Given this list of marker genes PDZRN3, TXLNG, SNRPD1, CREBRF (NCBI Gene Id 153222), DOCK3, SRF, DYNLL1, SMOC1, MARK1, PIM1, RBBP6, TOB1, PPP3CB, PUM2, DNAJC21, PTEN, PIK3R1, NEUROD6, SORCS1, SLC12A5, ELAVL2, GABRB3, AFF3, GAB2, G3BP2, ID4, UNC5C, NCOA6, CADM1, CNPY3, SP5, ARHGAP5, TSC22D2, BCORL1, REV1, MAP3K7, DCC, TBX2, IRX5, DENND2B, SRSF1, H3-3B, FGF13, CELF2, C19orf73, STK4, SLC10A7, SRSF3, ABHD17B, PTPN12, NFAT5, COPS7B, MAML3, FOXO1, SRGAP3 (SLIT-ROBO Rho GTPase activating protein 3), BTAF1, ARMC8, CNTNAP4, here is a description of the gene set: Genes having at least one occurence of the motif GTACAGG in their 3' untranslated region. The motif represents putative target (that is, seed match) of human mature miRNA hsa-miR-486 (v7.1 miRBase). Human Gene Set: GTACAGG_MIR486 species: Homo sapiens